Given this list of marker genes VDAC1, NUDCD1, TOMM5 (NCBI Gene Id 644560), RFC4, CMSS1, C14orf119, PSMG1, SLC25A32, RRP7A, TMEM140, PUS3, CCT6A, UTP14C, LRRC59, ARHGAP18, NAXE, CCT4, ZMYND19, PHLDA1, NAB2, MPLKIP, KEAP1, ZNF234, VTI1B, ZNF443, SNRPD3, PPP1R14B, PIGM, LCP2, DNAJC17, SAMM50, RUVBL2, FAM174C, FRMD4B, SPRY1, NANP, CTNS, ALDOA, ATP1B3, POP4, EIF2B2, QDPR, POLE2, CDC16, UBL5, PSMB2, GRK3, TBCCD1, IMP3, XPOT, BCL2A1, XCL1, ERCC6, POLR2F, TOP1MT (NCBI Gene Id 116447), RCC1L, IL2RA, GNL2, ZBTB6, DNLZ, EED, SEC11C, PTK2 (NCBI Gene Id 5747), TXNL4A, DNPH1, POGLUT1, MIR3667HG, MRPL17, PKIA, LYAR, SLC29A1, GNG8, POLR3H, POLR1G, DDX10, NAB1, MFSD2A, GPN3, PRADC1, PARS2, KCNJ2, SNRPG, TIAM1, CCDC86, MICOS13, IL18R1, KPNA2, B4GALT5, HSD17B10, MLYCD, PSMD8, ARMC6, PEX5, RAB11FIP1, RAB27A, HOMER1, GMPPB, NLE1, VBP1, PGD, MOB3C, GON7, SLC25A15, NFXL1, TUBB, FAM114A2, MED7, NT5E, ALKBH2, NAA30, PITPNA, PRDX4 (peroxiredoxin 4), FYCO1, HSPD1, LBHD1, ELMO3, SCFD2, JAML, CACYBP, RANBP1, MTNAP1, UCK2, ACOX1, UTP18, RBM28, PRDX1, POLR2H, CD200, PITPNB, MLH3, ADGRA3, MFSD3, MMACHC, GTDC1, PPP1CA, CHCHD6, ITGA3, PRMT1, IL1R1, PPIL1, FLAD1, UTP11, TMEM223, URB2, GEM, ALG3, EIF4E2, CHAC2, CSTF3, ORMDL2, UCHL3, TP53BP1, SLC7A1, NUP37, LAPTM4B, GBP2, STX6 (syntaxin 6), SDF2L1, WDR3, PEAK1, YARS2, ZMYM6 (NCBI Gene Id 9204), COA3, POLD2, TRAP1, SH2D2A, RUVBL1 (NCBI Gene Id 8607), RLIG1, TIMM10B, MYB, MRPL20, FAM241A, PTPN22, BACH2, CRIM1, ERP44, NR0B1, GOT2, NUBP1 (NUBP iron-sulfur cluster assembly factor 1, cytosolic), HYOU1, GEMIN6, ZNF557, ZNF470, OSBPL3, UTP15, ISG20L2, TMEM126B, SAYSD1, PAICS, NANS, TOLLIP, WDR36, COPRS, TIMM13, HAUS7, SFT2D2, IL21R, TBL2, ADO, here is a description of the gene set: studied in species Homo sapiens Genes down-regulated in comparison of untreated CD4 T cells at 0 h versus the untreated cells at 6 h. Human Gene Set: GSE17974_0H_VS_6H_IN_VITRO_ACT_CD4_TCELL_DN from publication Elo LL, Järvenpää H, Tuomela S, Raghav S, Ahlfors H, Laurila K, Gupta B, Lund RJ, Tahvanainen J, Hawkins RD, Oresic M, Lähdesmäki H, Rasool O, Rao KV, Aittokallio T, Lahesmaa R (PMID 20620947) The aim of this dataset was to study in detail the transcription kinetics initiated by cytokine IL-4 in early differentiation of Th2 cells.